The following is a description of a gene set: Human Gene Set: GSE2770_UNTREATED_VS_IL4_TREATED_ACT_CD4_TCELL_2H_UP from publication Lund R, Aittokallio T, Nevalainen O, Lahesmaa R (PMID 14607935) Th1 and Th2 cells arise from a common precursor cell in response to triggering through the TCR and cytokine receptors for IL-12 or IL-4. This leads to activation of complex signaling pathways, which are not known in detail. Disturbances in the balance between type 1 and type 2 responses can lead to certain immune-mediated diseases. Thus, it is important to understand how Th1 and Th2 cells are generated. To clarify the mechanisms as to how IL-12 and IL-4 induce Th1 and Th2 differentiation and how TGF-beta can inhibit this process, we have used oligonucleotide arrays to examine the early polarization of Th1 and Th2 cells in the presence and absence of TGF-beta after 0, 2, 6 and 48 hours of polarization. studied in species Homo sapiens Genes up-regulated in CD4 T cells: untreated (0h) versus activated by anti-CD3 and anti-CD28 and then stimulated by IL4 (2h)., and this is the list of marker genes: CMPK2, NDE1, SLITRK6, CENPH, SAPCD2, CLEC5A, CDKN3, LGALS1, ATP6V1G1, HS3ST2, STAU1, MX2, DENND1A, DCAF5, INSM1, PRICKLE3, CDCA8, RNPS1, ICAM5, MSRB1, KCTD2, PAK4, WRN, CDHR4, TNFRSF4, EIF2A, MELK, RER1, PI4K2B, HNRNPD, DBNL, MAF, METTL27, SHLD1, MYH7B, SPAG5, TNFRSF11A, MESP1, CYSLTR2, SEMA4C, TEX30, MID1, CAPN3, SYNE2, UBE2G2, CACNA1B, CCDC18, GINS1, SEMA4D, AURKA, GDA, FZR1, WDR33, ARHGAP1, GAL, CYP3A7, KHDRBS1, PRELID1, SYCE1, PTGR2, SNCA, ELAVL1, DNAJC22, TEX10 (testis expressed 10), CMAS, CSF1, MYPOP, ZW10, STIL, CDCA2, CIMIP6, TIMP4 (NCBI Gene Id 7079), JPT1, KNL1, SMARCB1, CKAP2L, NDUFA8, UBE2Z, C1QC, MED10, DBN1, TAPBP, SDCCAG8 (NCBI Gene Id 10806), NUP214, LCT, GNB4, LAG3 (lymphocyte activating 3), RASSF3, CXCR6, HDGF, SCN1A, PYCR2, IRF7, ATF5, COL19A1 (NCBI Gene Id 7950), FJX1, PCDHA12, PLEKHH1, POU2F2, RGS20, SYT7, SYTL2, BEND6, ZNF710, LGALS9B, MPEG1, CLDN9, OXCT2, PHF14, IRF4, ECSCR, PPP1R17, DAP, E2F5, MLLT1, EEF1D, IPPK, SMAD6 (SMAD family member 6), RILPL2, CXCL10, MVK, HIC2, FBXL18, CDH2, RPA3, PON2, PKP4, ODF4, LCP1, PTDSS1, TGFBI, PSEN1, PBK, PCDH8 (NCBI Gene Id 5100), CILP, SLC5A2, CYB561D2, ATP1B1, SLC7A5, SERAC1, FGD1, SH2D2A, TSPOAP1, TRAFD1, PPP1R14C, KIDINS220, NDUFC2, C19orf33, DLG4, CHCHD10, GPIHBP1, PROSER1, KIF18A, MTHFD2, SERPINH1, TMEM158, PSMD2, NSMCE2, DEPDC1B, NSMAF, FGFRL1, PTHLH, SLC4A1, ARPC1A, TMEM47, CCDC181, AHNAK2, DNM2, PRSS23, CDC123, RSRP1, TCFL5, CD96, FOXM1, NUP62, TIMP2, RPL22, TBC1D13, STMP1, DNAJC2, TBX21, ABCC6, GBP6, CST8, SRGAP1, IFIT1, ITGB5, ARID5A, LIN9, FSHR, QPCTL, CDKN2C, CBS, MND1, MOGAT1, SNX11, PDCD1, NDUFB9, FABP1, BABAM1